Given this list of marker genes FRS2, SEC24A, TMX4, FSD1L, IFNA17, ZBTB2, CERS2, TBL1XR1, CFL2, HTRA4 (NCBI Gene Id 203100), WASHC5, DEK, ZNF714 (zinc finger protein 714), REPS2, HMCN1, CYRIB, SS18, LRRFIP2, PATE4, LRRC15, ABHD13, BNC2, SAMD12, MTCL3, WIPI1, POC1B, KIAA0408, DBN1 (NCBI Gene Id 1627), COX15, STT3B, SH2D4B, CEP350, RAPGEF2, SMG7, EIF5AL1, TMEM132D, PTCHD4, ANTXR1, RAB6A, SPRY2, RSF1, MS4A3, SOX2, RAD23B, TSC22D2 (NCBI Gene Id 9819), ZNF431 (zinc finger protein 431), TMEM72, RARB, SLF1, ZNF677, SOCS7, CSPG5, ZNF575, IFNA10, EPHA10, RAB6C, KCNB2, RBMXL1, CCDC82, NSUN7, SMG1, ZNF365, DUSP12, NQO1, CDK14, RNF169, SLITRK3, PDS5B, SEMA3A, LRAT, KIAA0753, CYB5R4, COL11A1, CAAP1 (NCBI Gene Id 79886), PRRC1, CKAP5 (NCBI Gene Id 9793), LMLN, RAD51D, here is a description of the gene set: Genes predicted to be targets of miRBase v22 microRNA hsa-miR-4659a-5p in miRDB v6.0 with MirTarget v4 prediction scores > 80 (high confidence targets). Human Gene Set: MIR4659A_5P species: Homo sapiens from publication Chen Y, Wang X (PMID 31504780)